The following is a description of a gene set: part of: Cholesterol biosynthesis Reactome Pathway: Lanosterol biosynthesis studied in species Homo sapiens Cholesterol biosynthesis begins with the transformation of cytosolic acetyl CoA into lanosterol in a sequence of 15 reactions. The third of these, the reduction of beta-hydroxymethylglutaryl-coenzyme A (bHMG-CoA) to mevalonate (MVA) by bHMG-CoA reductase (HMGCR) is the tightly-regulated, rate-limiting step of cholesterol biosynthesis. It is also the target of the statin class of drugs.<p>Cholesterol biosynthesis is altered in mice harboring mutations that block peroxisome assembly, suggesting that some steps of lanosterol synthesis might occur in peroxisomes (Faust & Kovacs 2014). These effects could be indirect, however, mediated by cellular ER stress responses to the peroxisome deficiency, consistent with the observation that absence of functional peroxisomes does not lead to deficiency of enzymes involved in cholesterol biosynthesis either in mutant mice or in peroxisome-deficient humans. All the steps of this pathway have therefore been localized to the cytosol, mediated by cytosolic or ER membrane-associated enzymes.<p>Statins are a class of medications that lower cholesterol levels in the blood. They work by inhibiting an enzyme called hydroxymethylglutaryl-coenzyme A (HMG-CoA) reductase, which is involved in the production of cholesterol in the liver., and this is the list of marker genes: PLPP6, ACAT2 (acetyl-CoA acetyltransferase 2), PMVK, IDI2, HMGCS1, LSS, MVD, HMGCR, IDI1, FDFT1, MVK, FDPS, GGPS1, SQLE (squalene epoxidase)